Given this list of marker genes MCOLN1, SLC11A1 (NCBI Gene Id 6556), SLC40A1, SLC48A1, SLC11A2, SLC39A8, HEPH, IFNG, HAMP, SLC39A14, MIR210, SLC25A28 (solute carrier family 25 member 28), STEAP2, MMGT1, ABCB6, SCARA5, MCOLN2, ISCU, LCN2, ABCC5, SLC25A37, TTYH1, ABCB7, here is a description of the gene set: species: Homo sapiens Human Gene Set: GOBP_IRON_ION_TRANSMEMBRANE_TRANSPORT A process in which an iron ion is transported from one side of a membrane to the other by means of some agent such as a transporter or pore.